Given this list of marker genes GDPD1, GDPD3, NAAA, GDE1, NAPEPLD, here is a description of the gene set: Human Gene Set: GOBP_N_ACYLETHANOLAMINE_METABOLIC_PROCESS The chemical reactions and pathways involving N-acylethanolamines. An N-acylethanolamine is an ethanolamine substituted at nitrogen by an acyl group. species: Homo sapiens